Given this list of marker genes PBX3, CCNI, GARS1, RPE, EPHA4, TP53, PSMB9, PSME4 (proteasome activator subunit 4), STC2, MTHFD2, CYP2E1, IGF1R, HUWE1, DYNC1H1, HPCAL1, BASP1, KLF5, MARCKS, BRD2, F3, TGM3, TIPARP, ETS2, NET1, SMYD5, COL7A1, TRIP12 (NCBI Gene Id 9320), SLC12A4, RING1, GNB1, UBR4, BET1, ITGA2, ASS1, GTF2I, MGAT2, PPIF, KLF10, PTPN13, FNDC3A, PDE6A, CCN1, APEX1, SERPINH1, AANAT, SLC12A2, CLIC1, REV3L, COL11A2, RBMS1P1, NOP2, MYO1E, RGS2, TRIO, XBP1, ADSL, SERP1, TP63, CADM1, DAXX (death domain associated protein), KLF4, HTRA2, SLC20A1, IL1R1, TARS1, MYC, SRPK2, EEF1A1, PCDH7, TFAP2A, TNFSF4, LAMA5, PPP2R1B, LIMK2, GADD45B, EXT1, USP22, ELL2 (NCBI Gene Id 22936), ERCC5, ZNF282, PTGS2, HERPUD1, PNN, here is a description of the gene set: Human Gene Set: NGUYEN_NOTCH1_TARGETS_DN from publication Nguyen BC, Lefort K, Mandinova A, Antonini D, Devgan V, Della Gatta G, Koster MI, Zhang Z, Wang J, Tommasi di Vignano A, Kitajewski J, Chiorino G, Roop DR, Missero C, Dotto GP (PMID 16618808) Genes down-regulated in primary keratinocytes by expression of constantly active NOTCH1. studied in species Homo sapiens Notch signaling promotes commitment of keratinocytes to differentiation and suppresses tumorigenesis. p63, a p53 family member, has been implicated in establishment of the keratinocyte cell fate and/or maintenance of epithelial self-renewal. Here we show that p63 expression is suppressed by Notch1 activation in both mouse and human keratinocytes through a mechanism independent of cell cycle withdrawal and requiring down-modulation of selected interferon-responsive genes, including IRF7 and/or IRF3. In turn, elevated p63 expression counteracts the ability of Notch1 to restrict growth and promote differentiation. p63 functions as a selective modulator of Notch1-dependent transcription and function, with the Hes-1 gene as one of its direct negative targets. Thus, a complex cross-talk between Notch and p63 is involved in the balance between keratinocyte self-renewal and differentiation.